Given this list of marker genes ADIPOQ, NR1H4, LDLR, SOAT1, APOC3, LDLRAP1, MIR199A1, HNRNPK, ITGB3, CES3, MIR185 (microRNA 185), IL19, MIR27A, ANXA2, SCARB1, NCEH1, COMMD1, MIR133A1, DGAT2, KHSRP, ITGAV, MIR148A, HMOX1, MIR27B, MIR17, EHD1, CD36, SOAT2, LIPA, PCSK9, CNPY2, TREM2, APOB, CSK, FGF21, MYLIP, ABCC8, here is a description of the gene set: Human Gene Set: GOBP_LOW_DENSITY_LIPOPROTEIN_PARTICLE_CLEARANCE The process in which a low-density lipoprotein particle is removed from the blood via receptor-mediated endocytosis and its constituent parts degraded. studied in species Homo sapiens